Given this list of marker genes CDK9, tat, CCNT1, here is a description of the gene set: species: Homo sapiens part of: Host Interactions of HIV factors Reactome Pathway: Interactions of Tat with host cellular proteins The elongation of HIV-1 mRNA depends upon the interaction of Tat with the host P-TEFb complex.